The following is a description of a gene set: Mouse Gene Set: GOBP_CYCLIC_NUCLEOTIDE_METABOLIC_PROCESS The chemical reactions and pathways involving a cyclic nucleotide, a nucleotide in which the phosphate group is in diester linkage to two positions on the sugar residue. species: Mus musculus, and this is the list of marker genes: Adcy2, Gucy2g, Atp2b2, Pde7a (phosphodiesterase 7A), Cnp, Pde9a, Nppb, Pde4d, Gucy2c, Cacnb4, Adcy9, Epha2, Pde5a (NCBI Gene Id 242202), Pth2, Adcy3, Pde2a, Adcy10, Adcy8, Adcy7, Gucy1a1, Nppa, Npr1, Pde8a, Gucy2e, Adcy4, Npr2, Pde7b, Pde4a, Hrh3, Adcy1, Pde1a, Pde8b, Adcy6, Nppc, Pde10a, Pde4c, Gucy2f, Adcy5, Ampd2, Rora, Gucy1b1, Gucy2d